Given this list of marker genes TNKS2, PARP10, PARP12, PARP15, TIPARP, PARP11, PARP1, PARP3, PARP2, PARP4, PARP6, TNKS, PARP16, here is a description of the gene set: studied in species Homo sapiens Catalysis of the reaction: L-aspartyl- + NAD+ = 4-O-(ADP-D-ribosyl)-L-aspartyl- + nicotinamide. Human Gene Set: GOMF_NADPLUS_PROTEIN_ASPARTATE_ADP_RIBOSYLTRANSFERASE_ACTIVITY